Given this list of marker genes LMOD3, TTN, ACTC1, TCAP, ACTA1, PROX1 (NCBI Gene Id 5629), here is a description of the gene set: The aggregation, arrangement and bonding together of proteins to form the actin-based thin filaments of myofibrils in skeletal muscle. Human Gene Set: GOBP_SKELETAL_MUSCLE_THIN_FILAMENT_ASSEMBLY species: Homo sapiens